Given this list of marker genes MYO5A, NAF1, USB1, FAS, NHP2, CTC1, RPA1, EDNRB, DSTYK, SNAI2, KITLG, INSR, ACD, TFAP2A, RECQL4, SOX10, WRAP53, TYMS, MITF, POT1, EDN3, TERC, SPRTN, NPM1, RAB27A, PTPN22, MTAP, RTEL1, TERT, TTI1, TYR, ATM, DKC1, TINF2, NOP10, ZNF699, PARN (poly(A)-specific ribonuclease), MLXIPL, DPP9, PSMB8, WRN, ELN, ERCC8, BRCC3, STN1, PAX3, ERCC6, MDM2, LMNA, SLC5A6, here is a description of the gene set: Development of gray hair at a younger than normal age. studied in species Homo sapiens Premature graying of hair Human Gene Set: HP_PREMATURE_GRAYING_OF_HAIR